Given this list of marker genes CDH11, AGXT2, UBA2, PUS1, AARSD1, PTCD2, NOP56, CCAR2 (cell cycle and apoptosis regulator 2), LTV1, SLC25A25, ALKBH6, BFAR, FUT3, RRS1, FAM131A, TOR1B, PTPN1, TEFM, DERL2, ADARB1, PIP4K2C, TMCO3, CDK7, MCTS1, LINC01010, GNPNAT1, SUSD2, CENPV, LINC00667, CDC26, MAGEA5P, C1orf54, ASB14, MATK, APOBEC4, NAT1, LINC02483, NDUFA5, ELOC, FLNB, NMB, RANBP3L, ATIC, PHLPP2, ATXN10, CYLC2, SRPRB, SLC50A1, JMJD6, IQCF5 (IQ motif containing F5), XIRP2, PMAIP1, DUS2, LNPK (lunapark, ER junction formation factor), MYBBP1A, TFB2M, ACADM, FAM13B, EBNA1BP2, SNAPC5 (small nuclear RNA activating complex polypeptide 5, NCBI Gene Id 10302), ARL1, LRP6, RAB23, MBLAC1 (NCBI Gene Id 402572), METTL22, MYL11, DHX29, TMEM38B, ASB5, SPATS2, PRIM1, NUS1 (NCBI Gene Id 116150), ZNF407-AS1 (ZNF407 antisense RNA 1), ZFAND6, LINC03043, UBE2NL, LINC00968, RHOF, MTAP, SIGLEC6, TMEM91, BRF2, DEFB132, MRPS26, LINC02893, STX4, ACSS3, STAG3, TUBE1, ACTR6, GMPS, NIP7, TAP2, HOXC11, CRLS1, NIBAN1, MEIS1, SCO1, CDC27, FYN, DCUN1D5, LONRF3, DGUOK, SLC25A35, COX7B, CADM2, CEP57L1, TRIAP1, B3GLCT, CYB561D1, RYR3, FAM78B, TIMM21, CTNNAL1, GALNT12, SMCO4, SYTL1, HOXB6, SPSB1, ECH1, BCCIP, MRPL39, MUC2, IPP, RHOBTB2, MDGA2 (MAM domain containing glycosylphosphatidylinositol anchor 2), HMGB3P1, ACER3, AIMP2 (aminoacyl tRNA synthetase complex interacting multifunctional protein 2), LARP1B, FH, TMC6, ZBTB21, C2orf74, LYPLA1, FBXO15, HM13, ENTHD1, XPO4, CMAS, MAPK6, E2F6 (E2F transcription factor 6), CIB1, SLX9, LINC00592, CYP1A1, KBTBD8, SIGLEC17P, UNK, NMNAT2, BLOC1S4, TAOK3, COX7A2, MYO1E, COPZ1, CD52, PON1, PAPSS1, MESD, ATP5MK, SSBP3, SLC22A4 (NCBI Gene Id 6583), LAYN, LINC03007 (long intergenic non-protein coding RNA 3007), DPPA5P4, COX6B2, SLC25A15, ITGB1, MAPDA, KNSTRN, LINC01348, BPNT2, CFAP47, KLK7, HILPDA, SLC22A5, SLC30A5, CALN1, RBM14, AIRIM, MRPS18C, SYVN1, PSMC3, TMEM69, PSMA4, RASAL2, ACTN1, CRIPT, RMDN2, UCHL5, DERL1, SRPRA, DNAJC24, TTC8, SLC35A2, here is a description of the gene set: Genes down-regulated in comparison of macrophages treated with control (hIgG1) versus those treated with TNFRSF6B. Human Gene Set: GSE10856_CTRL_VS_TNFRSF6B_IN_MACROPHAGE_DN species: Homo sapiens Decoy receptor 3 (DcR3) is a member of the TNF receptor superfamily and is up-regulated in tumors that originate from a diversity of lineages. DcR3 is capable of promoting angiogenesis, inducing dendritic cell apoptosis, and modulating macrophage differentiation. Since tumor-associated macrophages (TAMs) are the major infiltrating leukocytes in most malignant tumors, we used microarray technology to investigate whether DcR3 contributes to the development of TAMs. Among the DcR3-modulated genes expressed by TAMs, those that encode proteins involved in MHC class II (MHC-II)-dependent antigen presentation were down-regulated substantially, together with the master regulator of MHC-II expression (the class II transactivator, CIITA). The ERK- and JNK-induced deacetylation of histones associated with the CIITA promoters was responsible for DcR3-mediated down-regulation of MHC-II expression. Furthermore, the expression level of DcR3 in cancer cells correlated inversely with HLA-DR levels on TAMs and with the overall survival time of pancreatic cancer patients. The role of DcR3 in the development of TAMs was further confirmed using transgenic mice over-expressing DcR3. This elucidates the molecular mechanism of impaired MHC-II-mediated antigen presentation by TAMs, and raises the possibility that subversion of TAM-induced immunosuppression via inhibition of DcR3 expression might represent a target for the design of new therapeutics. from publication Chang YC, Chen TC, Lee CT, Yang CY, Wang HW, Wang CC, Hsieh SL (PMID 18349319)